The following is a description of a gene set: species: Homo sapiens Human Gene Set: REACTOME_SIGNAL_AMPLIFICATION Signal amplification, and this is the list of marker genes: GNB5, TBXA2R, GNG13, P2RY1, P2RY12, GNB2, GNAI1, GNG2, GNG8, AAMP, GNG10, GNB3, GNA11, GNB1, GNG11, MAPK14, GNG3, GNB4 (G protein subunit beta 4), GNAQ, GNGT1, GNG7, GNAT3, GNG4, PLA2G4A, GNA14, GNA15, GNG5, GNAI3, GNAI2, GNGT2, GNG12, GNA13, SRC